Given this list of marker genes Washc1, Ska2, Ddb1, Ska3, Cenpe, Dcaf13, Aspm, Fbxo5, Pten, Aurka, Golga2, Ska1, Washc5 (WASH complex subunit 5), Septin1, Ndc80, Ccnb2, here is a description of the gene set: species: Mus musculus Mouse Gene Set: GOBP_MEIOTIC_SPINDLE_ASSEMBLY The aggregation, arrangement and bonding together of a set of components to form the spindle that contributes to the process of meiosis.